The following is a description of a gene set: Mouse Gene Set: CUI_T_CELL_GD_IL7_RESPONSE_UP Cytokines mediate cell-cell communication in the immune system and represent important therapeutic targets. A myriad of studies have highlighted their central role in immune function, yet we lack a global view of the cellular responses of each immune cell type to each cytokine. To address this gap, the authors created the Immune Dictionary, a compendium of single-cell transcriptomic profiles of more than 17 immune cell types in response to each of 86 cytokines (>1,400 cytokine-cell type combinations) in mouse lymph nodes in vivo. A cytokine-centric view of the dictionary revealed that most cytokines induce highly cell-type-specific responses. For example, the inflammatory cytokine interleukin-1β induces distinct gene programmes in almost every cell type. A cell-type-centric view of the dictionary identified more than 66 cytokine-driven cellular polarization states across immune cell types, including previously uncharacterized states such as an interleukin-18-induced polyfunctional natural killer cell state. from publication Cui A, Huang T, Li S, Ma A, Pérez JL, Sander C, Keskin DB, Wu CJ, Fraenkel E, Hacohen N (PMID 38057668) Genes positively differentially expressed in cell type: γδ T cell upon treatment with cytokine: IL-7 in mouse lymph nodes in vivo. studied in species Mus musculus, and this is the list of marker genes: Cish, Atp5f1d, Mif, Fam136a, Yrdc, Eif4e, Mrto4, Ptpn2, Cxcl10, Mthfd1, Anp32b, U2af1, Nip7, Pum3, Selenow, Trac, Aen, Kmt5a, Uqcc2, Cdv3 (NCBI Gene Id 97532), Rhoa, Cdk6, Pim2, Arpp19, Mogs, Igtp, Nars1, Atp2a2, Tbca, Hars1, Atp5mc3, Mrps15, Utp18, Ndufa11, Ydjc, Lta, Nle1, Phf5a, Rmi2, G3bp1, Atp1a1, Snrpc (U1 small nuclear ribonucleoprotein C), Clns1a, Nadk, Denr, Ppp1r14b, Dnajc2, Ssr2, Smyd5, Tomm20, Csnk2b, Ifrd2, Lap3, Irf7, Nol12, Treml2, Lgals3bp, Trmt61a, Psma2, Prdx1, Rrp1b, Cops6, Psmb6, Mthfd2, Hspd1, Nop2, Pcca, Plekhj1, Psma4, Srsf10, Psmb7, Eno1, Mrps7, Syncrip, Hspe1, Polr1d, Ak2, Bcap29, Eif3c, Nop16, Tuba1b, Ndufb7, Ndufaf4, Pfn1, Hbegf (NCBI Gene Id 225370), Nop10, Ywhaq, Ndufs4, Eif2s1, Xpot, Gars1, Rangrf, Ifi47, Wars1, Kars1 (NCBI Gene Id 85305), Rars1, Polr1g, Lman2, Grwd1, Mrps18b, Psmb4, Gzmb, Mrpl36, Atp5f1b, Fubp1, Uqcrb, Impdh1, Mrpl54 (mitochondrial ribosomal protein L54), Dnajc21, Pak1ip1, Mcm2, Eif5a, Chchd2, Hnrnpa2b1, Eif3j1, Snrpd2, Magt1, Fkbp4, Bola2, Ybx3 (NCBI Gene Id 56449), Mpc1, Mars1, Tex2, Hnrnpu, Ivns1abp, Hspa4, Cd48, Strap, Tasp1, Cox5b, Timm9, Trgc2, Ppp4c, Tpm3, Snrpa1, Psmc5, Rrp12, Yif1a, Dnaja2, Mrpl51, Gnl3, Hectd1 (HECT domain E3 ubiquitin protein ligase 1), Zfp706, Eef1e1, Psma3 (NCBI Gene Id 19167), Gpatch4, Aprt, Atp5mk, Utp14a, Kpnb1, Hnrnpab, Eif4a1, Wdr43, Utp11, Atp5pb, Pa2g4, Hypk, Slc35a4, Eif3l, Cdk4, Lars1, Alkbh1, Csf2, Capza2, Ssrp1, Ipo5, Ddx10, Bcl2, Rcc2, Atp5mc1, Rsl24d1, Sem1, Bzw2, Ruvbl2, Pfdn2, Srsf2, Cluh, Nsun2, Nmd3, Sigmar1, Cysltr1, Txnl4a, Fdps, Exosc4, Larp4, Creld2, Sar1a, Gcsh, Coq2, Higd1a, Ddx21, Eloc, Dnlz, Uqcrq, Dcun1d5, Ufm1, Iars1, Gfer, Hnrnpc, Mdfic, Ddx18, Socs3, Psmd2, Vps29, Atad3a, Cycs, Aldh18a1, Trappc4, Surf2, Eif2s2, Bcl2l1, Mydgf, Phgdh, H13 (NCBI Gene Id 99254), Gimap3, Stat1, Tomm40, Utp20, St13, Dnajc19, Pdia6, Sarnp (NCBI Gene Id 66118), Lsm4, Furin, Gtf3c6, Irgm1, Ncbp2, Ly6a (NCBI Gene Id 17065), Pdia4, Rexo2, Rras2, Dad1, Srp9, Bcas2, Tomm5, Bsg, Trmt1, Surf4, Shmt1, Gbp4, Bax, Zcrb1 (NCBI Gene Id 67197), Eif4g1, Eef1g (eukaryotic translation elongation factor 1 gamma), Ssr4, Prelid3b, Ppp5c, Erh, Lsm7, Nap1l1, Eif4ebp1, Cnbp, Avpi1, Ewsr1, Mrpl30, Hsp90ab1 (heat shock protein 90 alpha (cytosolic), class B member 1), Nop56, Cfl1, Ube2i, Lat, Sdf2l1, Hnrnpll, Atic, Mettl1, Rrp9, Snrpb, Ywhah, Exosc8, Eif3b, Glrx3, Txn2, Grpel1, Tubb4b, Ube2l3, Trgc4, Psmg4, Abcf1, Psma5, Ifi35, Gapdh, Elavl1, Stub1, Npm1, Rrs1, Socs1, Gart, Mphosph10 (M-phase phosphoprotein 10 (U3 small nucleolar ribonucleoprotein)), Mia2, Txn1, Rnf4, Sms, Hikeshi, Phb2, Ube2m, Timm8a1, Slc25a5, Tubb5, Caprin1, Ywhab, Chchd1, Stat3, Nr2c2ap, Mrpl17 (NCBI Gene Id 27397), Il2ra, Agpat5, Exosc3 (NCBI Gene Id 66362), Mdh2, Cmtm6, Ranbp1, Isg15, Pusl1, Pinx1, Ccnd2, Mbd3, Snx3, Serpina3g (serine (or cysteine) peptidase inhibitor, clade A, member 3G), Sdad1, Imp4, Llph, Ehd1, Psmb8, Npm3, Tex264, Mrpl21, Kti12, Xbp1 (NCBI Gene Id 52219), Mapkapk2, Slc35b1 (NCBI Gene Id 22233), Acsl5 (acyl-CoA synthetase long-chain family member 5), Ndufb6, Tnfaip8 (NCBI Gene Id 106869), Ubl4a, Fabp5, Bop1 (block of proliferation 1), Snrpd3, Ncl, Hint1 (histidine triad nucleotide binding protein 1, NCBI Gene Id 15254), Ybx1, Eif3d, Smyd2, Thap12, Pals2, Rrp15, Nhp2, Hspa8, Wdr46, Etf1, Nudcd2, Timm13, Taf10, Imp3, Mrpl23, Elovl1, Vim, Ppia, Stoml2, Dnttip2, Tnfsf11, Smap2, Alyref, Rbx1, Gspt1, Noc4l, Magoh, Zbp1, Cct2, Zfp593, Ndufab1, Timm10, Cnih4, Nudt19, Ptges3, Ftsj3, Trir, Dynll1, Pim1, Septin9, Rsl1d1, Cetn3, Atg3, Canx, Rala, Hprt1, Mtap, Psmb3, Tpi1, Fam162a, Pdia3 (NCBI Gene Id 18794), Isg20, Acadvl, Tpp2, Krtcap2, Eif5b, Chchd4, Flt3l, Tkt, Shmt2, Dctpp1 (NCBI Gene Id 66422), Ltv1, Srsf3, Bccip, Noc2l, Tagln2, Pon2, Ssb, Mak16, Cct3, Fasn, Manf, Hnrnpf, Sec61b, Snx15, Lfng, Rrp1, Abce1, Hsp90aa1, F2r, Cyb5b, Gnb1, Odc1, Mrps28, Ass1, Uchl3, Polr2f (NCBI Gene Id 69833), Psmd12, Hras, Sumo2, Prmt3, Atp6v1g1 (NCBI Gene Id 98834), Snrpf, Farsb, Prelid1, Glrx5, Eif4e2, Diablo (diablo, IAP-binding mitochondrial protein), Ddx27 (NCBI Gene Id 97020), Heatr1, Degs1, Prpf31, Banf1, Trp53, Timm17a, Wdr18, Rangap1, Rnf7, Tmed2, Cdc37, Pno1, Hdlbp, Metap2, Eif3g, Rad23a, Hnrnpa3, Ptma, Afg2a, Dtx1, Gadd45g, Med1, Hnrnpdl, Mrpl15, Smarca4, Rpp25l, Calm1, St6galnac4, Bysl (bystin-like), Naa50, Set (NCBI Gene Id 80406), Hnrnpd, Sod2, Naa15, Prrc2a, Psma6, Pus1, Cox17, Sf3b4, Eif3a, Gar1, Wdr83os, Ahsa1, Ddost, Hyou1, Mrps18c, Hdgf, Apex1, Larp1, Calr, Prmt1, Osm, Actg1, Bzw1, Impdh2, Hspa9, Hnrnpa1, Ppa1, Mrpl20, Ddx39b, Osbpl3 (oxysterol binding protein-like 3), Tmem147, Cox6a1, Ube2n, Pitpna, Cyp51, Med8, Pus7, Rbm8a, Eif1ax, Rwdd1, Lrrc59, Eif1, Mdn1, Pgk1, C1d, Nudc, Cers2, Hsd17b12, Nolc1, Cct4, Dnajc3, Ube2s, Mtrex, Znhit6, Ppp1r11, Cars1, Tmem238, Eef1d, Atp6v0e (NCBI Gene Id 11974), Cisd1, Adam8, Lsm6, Lgals1, Ciao2a, Ywhae, Fkbp1a, Tomm70a, Ppan, Tmem97, Ppat, Rnf126, Psmb2, Mrpl18, Eif6, Cdk2ap1, Gng5, Ndufa12, Ccdc86, Nasp (nuclear autoantigenic sperm protein (histone-binding)), Adh5, Tmed9, Nme1, Smu1, Pam16, Reep3, Wdr75, Sf3b3, Hnrnpk, Nop14, Rcl1, Bst2, Sco2, Ruvbl1, Aars1, Lsm12, Psma7, Snrpd1, Wdr3, Srsf7, Hsp90b1, Tcp1, Fkbp2, Nans, Arl4c, C1qbp, Pgam1, Abhd14a, Bud23, Casp8, Emc6, Pabpc4 (NCBI Gene Id 230721), Kcnq1ot1 (NCBI Gene Id 79200), Ung, Noc3l, Nat10 (N-acetyltransferase 10), Mybbp1a, Polr2h, Cacybp, Lyar, Hspa5, Galk1, Thumpd1, Cox5a, Serbp1, Slc16a6, Dph3, Gtpbp4, Eif1a, Cct5, Baz1a, Rpn1, Npepl1, Nop58, Herpud1, Psme3, Ccdc115, Laptm4a, Pkm, Eef1akmt4, Ppid, Guk1, Ltb4r1, Cox7c, Timm50, Dkc1, Igfbp4, Snu13, Ostc, Isyna1, Snrpa, Znrd2, Nifk, Psmb10, Stip1, Ldha, Tsr1, Suclg1, Cebpz, Mat2a, Pfdn6, Sars1, Psmd7, Mrps12, Hsph1, Morf4l2 (NCBI Gene Id 71961), Sema4b, Mrfap1, Mrpl12, Psme1, Rpf2, Dnajb11, Aimp2, Ubxn4, Cdc42, Pebp1, Prpf19, Srsf9, Cct7, Naf1, Tmed10, Uqcc4, Psmd1, Ran, Arhgdia (Rho GDP dissociation inhibitor alpha), Phb1, Slc3a2, Il2rb, Ndufaf8 (NADH:ubiquinone oxidoreductase complex assembly factor 8), Eif4a3, Mrpl11, Pprc1, Fbl, Tma16, Tuba4a, Nampt, Ndufb4, Psmd13, Cct8, Cndp2 (CNDP dipeptidase 2), Eprs1, Ebna1bp2, Mrpl41, Got2, Slc29a1, Srsf6, Pwp1, Tmem33, Cyc1, Vars1, Spcs3, Sec11c, Abcf2, Ccdc9, Uck2, Rbm3, Selenos, Pole4, Psme2, Smg5, Tmed5, Ddx39a, Coro2a, Prmt7, Tmem176b, Uqcr11, Ipo4, Spcs2, Ccdc124 (NCBI Gene Id 69153), Tars1, Mrps18a, Pcbp1, Lsm3, Lsm2, Srm, Umps, Psmb5, Cited4, Farsa, Gcn1